The following is a description of a gene set: studied in species Mus musculus Catalysis of the hydrolysis of peptide bonds by a mechanism in which water acts as a nucleophile, one or two metal ions hold the water molecule in place, and charged amino acid side chains are ligands for the metal ions. Mouse Gene Set: GOMF_METALLOPEPTIDASE_ACTIVITY, and this is the list of marker genes: Naaladl1, Brcc3dc, Zmpste24, Adam12, Metap2, Adam29, Cpa3, Enpep, Npepps, Mep1b, Pmpca, Stambpl1, Trhde, Cpb2, Adamts3, Lnpep, Agbl1, Mmp7, Mmp24, Vash1, Mme, Stambp, Adam11, Mmp21, Adamts19, Lvrn (NCBI Gene Id 74574), Prcp, Adam18, Adam32, Cpa1, Adamts9, Aopep, Kel, Clca4a, Tll2, Mmp10, Adam10, Eef1ece2, Bst2, Mmp12, Anpep, Npepl1, Adamts5, Pappa, Mmel1, Cpb1, Clca2, Mmp9, Adam21, Adamts6, Agbl3 (NCBI Gene Id 76223), Adamtsl2, Adamts20 (ADAM metallopeptidase with thrombospondin type 1 motif 20), Cpxm1, Adamts16, Mmp1a (NCBI Gene Id 83995), Adamts18, Brcc3, Cpa2, Uqcrc2, Lxn, Adamts13, Adamts17, Rnpep, Adam34l, Rnpepl1, Vash2, Lmln, Adamts4, Mipep, Mmp15, Metap1, Pitrm1, Thop1 (NCBI Gene Id 50492), Adam9, Adam26a (ADAM metallopeptidase domain 26A), Erap1, Naalad2, Bmp1, Clca1, Trabd2b, Timp2, Ngf, Folh1, Agbl4 (NCBI Gene Id 78933), Pappa2, Ide, Yme1l1, Prpf8 (NCBI Gene Id 52899), Rce1, Cpe, Nln, Prep, Matcap1, Ermp1, Clca3a1, Afg3l1, Cndp1, Mmp14, Adamts2, Agtpbp1, Amz2, Ece1, Afg3l2, Lta4h, Cpa5, Adam22, Adamts10, Adam25, Spock3, Ece2, Eif3f, Mmp2, Pepd, Ybey, Xpnpep3, Mmp8, Mmp13, Matcap2, Adamts1, Mpnd, Mbtps1 (NCBI Gene Id 68372), Psmd7, Mmp3, Spock1, Adam1a, Reck, Cpd, Cpa6 (NCBI Gene Id 329093), Adam20, Dpep1, Adamts7, Cpq, Cpz, Adamts15, Adam3, Atp23, Mmp20, Mmp1b, Xpnpep1, Nudt16, Cirop, Cops5, Mmp16, Adam6b, Adam23, Metap1d, Amz1, Adam4, Cpn1, Xpnpep2 (NCBI Gene Id 338497), Cpa4, Adam15, Timp1, Timp3, Dpep2, Mmp25 (NCBI Gene Id 240047), Adam30, Ace3, Adam39, Tll1, Adam2, Adam8, Cndp2, Agbl5, Mmp27, Adamts8, Adamts12, Ecel1, Nrdc, Agbl2, Mmp17, Eif3h, Mmp11, Gm4787, Adamts14, Adam34, Mmp28, Mep1a, Mmp19, Adam1b, Adamdec1, Adam28, Timp4, Phex, Adam6a, Mmp23, Fetub, Spg7, Cops6, Dnpep, Mbtps2, Adam19, Astl, Pmpcb, Oma1, Psmd14, Adam5, Adam33, Dpp3, Adam17, Cpm, Aebp1, Adam7, Mysm1, Lap3, Sprtn, Rarres1, Ace2, Adam24, Adam26b, Ace